Given this list of marker genes DHH, SLC25A24 (solute carrier family 25 member 24), TTC39A, TBP, CPE, TGM3, CCK, GJB3, USP22, CYP11B1, HYAL2, ANO3 (NCBI Gene Id 63982), CERNA1, KANK3, SMG1, KLHDC3 (kelch domain containing 3), SCAPER, EFCAB11, SPRY1, MYRF, SLC12A5 (solute carrier family 12 member 5), CACNA1D, RCVRN, CACNA1C, S1PR1, CPNE1, CCL16, MERTK, OTUD3, KCTD2, TBR1, PPBP, YTHDC2, OSMR, BRINP3, CRYM (crystallin mu), CCIN, PUM3, NTRK1, FANCI, ERC1, BICD1, PDIA4, TTC28, ZNF160, TPD52, SEC23B, LRRC23, RALGAPB, UBN1, LUM, ASIC2, OLFML2A, INPP5B, MAP3K13, BAG5, MMP11, TXLNA, SLC9A7, HSPB3, IFNA16, SNRPD1, MRPL28, TSHB, POLA2, IL1A, PEX2, PRIM2, RRAGB, HOXA10, SAPCD1, B4GALNT1, PPEF1, PCGF3, RAPGEF4 (Rap guanine nucleotide exchange factor 4, NCBI Gene Id 11069), PRLR, TYRO3, NOVA2, GABRB3, DUXAP10, BRME1, TAF13, FRMPD4, CHGA, INTS9, OLFM1, PHTF1, ITPKB, SND1, CCNT1, LPAR4, AQP2 (NCBI Gene Id 359), NDUFB6, RASGRP2, RBBP7, H1-4, RPE, MTCL1, RAD50, SGCE, KDM4B, TMCC2, COL8A1, RUVBL1, HP, TRAPPC3, MMP20, ABL1, SPIB, POU6F1, DIRAS3, INA, FAM131B, FNTB, ORC5, HABP4, AATK, MYH11, VNN1, FLNC, ZSCAN9, IL5, IL18R1, WWTR1, GCLC, EIF3J (eukaryotic translation initiation factor 3 subunit J), STK16, ADRB2, STXBP5L, PDE6B, HBBP1, SPECC1L, DNAJB5, TCAF1, AKT2, ACKR3, GFI1, MATN2, DIXDC1, HOXA9, WWP2, COL4A5, RYR3, MACIR, B4GALT6, ME3, CLEC3B, SLC27A2, SNRNP35, LILRA4, H1-3, AMOT, ZKSCAN4, NPR3, PAH, MLF2, KLHL35, PPM1E, CHRNA5, HARS1, TMEM109, LDOC1, TAF1B, OFD1, UTP20, DRD1, MDN1, C7, THBS2, DGCR2, REG1B, C6orf47, GPR182, ZBED4, IVL, BRS3, CCT6B, TGFB3, INPP5A, ZNF81, PKP4, SDHA, RAE1, COL4A4, RFXAP, KRT19, NPRL3, GDF11, SOX15, AJAP1, CCDC9, PGM5, COL21A1, HFE, UCP3, ST3GAL1, ERAP1, UPK3A, here is a description of the gene set: Genes down-regulated in comparison of dendritic cells (DC) exposed to L. major versus DCs exposed to T. gondii. Monocyte-derived dendritic cells (DC) and macrophages (MΦ) generated in vitro from the same individual blood donors were exposed to five different pathogens, and gene expression profiles were assessed by microarray analysis. Responses to Mycobacterium tuberculosis and to phylogenetically distinct protozoan (Leishmania major, L. donovani, Toxoplasma gondii) and helminth (Brugia malayi) parasites were examined, each of which produces chronic infections in humans yet vary considerably in the nature of the immune responses they trigger. Human Gene Set: GSE360_L_MAJOR_VS_T_GONDII_DC_DN species: Homo sapiens from publication Chaussabel D, Semnani RT, McDowell MA, Sacks D, Sher A, Nutman TB (PMID 12663451)